Given this list of marker genes Gm21823, Gm28899, Gm29255, Gm29577, Gm20903, Gm21111, Gm28423, Gm29110, Gm29312, Gm28739, Gm29573, Gm28699, Gm28125, Gm20813, Gm29108, Gm21790, Gm20867, Gm28969, Gm21155, Gm21875, Gm28377, Gm20814, Gm29144 (NCBI Gene Id 118568458), Gm20847, Gm21715, Gm21163, Gm20791, Gm21658, Gm28225, Gm20859, Gm21766, Gm21638, Gm21683, Gm21873, Gm28815, Gm20916, Gm21248, Gm21825, Gm21242, Gm28542, Gm28829, Gm20846, Gm28161, Gm20912, Gm29189, Gm21257, Gm28421, Gm28814, Gm21722, Gm21760, Gm28422, Gm20850, Gm28606, Gm29565 (predicted gene 29565), Gm20805, Gm28700, Gm21650, Gm29382, Gm21869, Gm29109, Gm20917, Gm28420, Gm28790, Gm21855, Gm20844, Gm29178, Gm20801, Gm20904, Gm21173, Gm21757, Gm20806, Gm29567, Gm28608, Gm20919, Gm28827, Gm21333, Gm29031, Gm21076 (NCBI Gene Id 108168670), Gm28741, Gm20902, Gm29190, Gm21922, Gm20841, Gm21919, Gm21198, Gm20800, Gm28678, Gm28677, Gm29564, Gm20849 (predicted gene, 20849), Gm21317, Gm28742, Gm21282 (predicted gene, 21282), Gm21829, Gm28787, Gm20848, Gm29617, Gm21344, Gm28789, Gm20808, Gm21728 (predicted gene, 21728), Gm20911, Gm21180, Gm28897, here is a description of the gene set: Mouse Gene Set: chrYD studied in species Mus musculus